The following is a description of a gene set: part of: Gap junction assembly The mechanism of connexin assembly into connexons has been well characterized. Two different types of connexons can be formed. A connexon containing six identical connexin molecules is referred to as an homomeric connexon, while a connexon containing at least two different connexin molecules is referred to as an heteromeric connexon. The connexin molecules making up an heteromeric connexon appear to belong to only one subgroup (alpha or beta); heteromeric connexons containing both alpha and beta subunits have not yet been observed. Indeed, an intrinsic signal in four amino acid positions appears to confer different physicochemical characteristics to certain connexins in the alpha and beta groups. These intrinsic signals are Cx specific, however (see Gemel et al., 2006). Therefore, additional yet unknown signals are required to regulate connexin compatibility and hetero-oligomerization. <br>The identification of the subcellular location at which gap junction assembly occurs has proven difficult. One explanation for this difficulty may be that the location of oligomerization for each connexon varies depending upon Cx type or cell type. Oligomerization has been observed after ER membrane insertion (Cx43, Cx32, Cx26), in the ER-Golgi-intermediate compartment (ERGIC) (Cx32) and inside the trans-Goligi network (Cx43). Reactome Pathway: Oligomerization of connexins into connexons species: Homo sapiens, and this is the list of marker genes: GJB1, GJA1, GJB2